Given this list of marker genes BOLA1, FASLG, HPX, EDN1, RHAG (NCBI Gene Id 6005), LYN, KCTD17, SCNN1B, CYP4F2, MT2A, MT1E, CNNM2, FLNA, PTH, GLUL, DRD3, ATP6V1G1, SELENOK, BAK1, SLC39A9, CA12 (NCBI Gene Id 771), TMTC4, TMEM94, HCRTR2, CALCA, KCNA1, CNR1, GRIK2, PRKCE, BNIP3, MIR1-1, ITPR3, SPX, FTHL17, MIR210, F2R, KCNA5, ASPH, COX10, ISCU, B2M, WNT5A, CCL15, ERC2, PLCL2, TMEM165, TRPV4, ATP2B3, CDH5, F2RL3 (NCBI Gene Id 9002), PACS2, TMCO1, ERFE, CYP27B1, TRPC5, XK, PDZD8, KEL, THY1, SLC12A6, IBTK, CASQ1, EDN2, MICU1, CCL5, PRKACA, CYB561, TF, SLC9B2, STK39, FTH1P19, CD19, CCDC47, CALR, SLC30A5 (solute carrier family 30 member 5), CYBA, HFE, NPPB, NOL3, SLC12A3, ANKH, ATP1A4, TRPV6, METTL21C, NUBP1, APP, CLCC1, SCNN1D, ATP2C2, BOLA2B, HJV, SLC12A9, TMTC2, CCL21, TMC6, KCNQ1, SLC31A1, ATP6AP1, NPSR1, PRND, STIM2, CORIN, ATP2A1, MLLT6, DRD2, SLC34A3, ANK3, PLN, CALM2, NHERF1, NTSR1, ATP1B1, SRI, RHD, ABL1, KCTD7, TPT1, CCDC115, EIF2AK1 (NCBI Gene Id 27102), GLRX3 (glutaredoxin 3), CCL19, TRPC4, CCL14, ATP6V1A, SLC39A14, PLCB3, STC1, TRDN, CCL11, ACVR2B, ATP6V1B1, CCL7, PDPK1, EDNRA, OTC, GHITM, PKHD1, MT3, CALM3 (calmodulin 3), AGT, THADA, SYPL2, PDE4D, NPY, KCNJ2, RHBG, ANKRD9 (NCBI Gene Id 122416), HCRTR1, ANK2, CHERP, SV2B, TNFSF11, ATP12A, CNNM1, HYAL2, IFNG, RMDN3, CIB2, XCR1, ATP4A, RAP1GDS1, PLCB2, S100A14, P2RY6, CX3CL1 (C-X3-C motif chemokine ligand 1), CLN3, MCUB, ATP4B, ZNHIT1, MT1A, P2RY1, TRPC1, PTH1R, KCNK16, SLC34A1 (solute carrier family 34 member 1), CCL23, HEPHL1, MYH7B, ALPL, TRPM8, PKD2, SCO2, RGN, SLC11A1, STEAP2, FXYD2, JPH1, SLC46A1, TRPA1, WNK4 (NCBI Gene Id 84361), SCN7A, DHRS7C, MIR93, ATOX1 (antioxidant 1 copper chaperone), TMPRSS3, RHCE, HAMP, CNNM4, MT1G, ITPR2, EPB42, HERPUD1, ELANE, CCDC22, ANXA6, FTMT, TMEM174, SLC10A7, TRIM24, HSP90B1, ATP2B4, OSBPL2, KL, CCR1, MT1H, ATP1A3, SLC35G1, TRPC3, PLCE1, C19orf12, BOLA2, HTT, STEAP4, PLCG1, EDNRB, BOK, SMAD1, SOD2, ATP13A2, SLC34A2, SLC1A3, WNK1, CCL3, CYP4F12, YWHAE, GPER1, SLC30A7, CEMIP, SNX10, SGCD, IL13, TMEM203, GSTO1, GRID2IP, NCOA4, SLC22A17, COX19, CALB1, NEO1 (neogenin 1), SLC39A4, SLC31A2, GPR12, TRPC7, CYP4A11, CORO1A, P2RX1, FGFR1, MAIP1, ENPP1, FLVCR1, LCN6, DRD1, SLC12A1, CXCR3, CACNA1S, TMEM38A, NPTN, TFR2, ATP2B1, SLC24A2, PTPN6, SLC39A8, GCM2, SLC24A1, TFRC, CAV2, TMPRSS6, HEXB, SLC1A1, ATP2A2, SMAD4, CUTC, MC3R (NCBI Gene Id 8203), ATP7B, TRPM2, PTPRC, SLC12A5, MECR, BCL2, CTRC, FECH, MT1M, PLCL1, CYP11B2, MCU, JPH4, BOLA3, TMC8, CXCL9, ATF4, SNCA, LCK, DISC1, RYR3, CLIC2, CD40, GRM5, HTR2B (NCBI Gene Id 3357), ADORA1, CHD7, CP, PLCH1, PRNP, MICU3, TPCN2, XIAP, TMEM38B, GSTM2, ENPP3, PTK2B, DRD4, SLC17A6, TGFB1, TRPM7 (transient receptor potential cation channel subfamily M member 7), CHRNA7, FKBP1A, FZD9, SPPL2C, FBXL5, STOML2, FTH1, SLC39A7, SLC30A2, CACNB2, GP5, SLC8A2, UPK3A, IL1A (interleukin 1 alpha), MYC, KCNMA1, FTL, XPR1, EXT1, BMP6, TRPV5, FKBP1B, ABCC6, SLC39A13 (NCBI Gene Id 91252), PML, TMEM178A, SLC12A7, LETMD1, FGF2, COMMD1, ABCB6, SV2A, FRRS1, CCR7, TMEM199, APLNR, ATP1A1, CASQ2, VAPB, ATP1B2, SLC17A8, HRC, EXT2, KDR, CISD1, GRM1, CCR2, HAP1, SLC25A27, PLCB1, SLC17A7, SLC8B1, DDIT3, AFG3L2 (AFG3 like matrix AAA peptidase subunit 2), HEPH, TMBIM6, SLC11A2, STIM1, IREB2, NAGLU, LCN2, ATP2C1, NPPC, PRKCB, WBP2NL, SLC12A8, MCOLN1, ATP6V0A2, TUNAR, P2RX7, DIAPH1, CAPN3, TBXAS1, LIME1, PSEN1, ATP13A4, FAM3A, F2, BDKRB1, GRINA, SLC8A3 (solute carrier family 8 member A3), SLC41A1, ATG5, SLC24A5, ALAS2, IMMT, CXCL11, CXCL12, CYBRD1, AP3B1, MT1F, RYR1, SCO1, PLCH2, CAV3, CAMK2D, SOD1, HTR2C, ADCY8, FAM20A, AKAP6, SLC30A9, FXN, FGFR4, CNGB1, DMTN, ATP13A1, NGF, RYR2, AGTR1, APOE, CDH23, CSRP3 (cysteine and glycine rich protein 3), CACNA1C, CXCL10, ITPR1 (NCBI Gene Id 619543), PSEN2, CCL13, ATP1A2, MT1B (NCBI Gene Id 81836), SCNN1A, CASR, NPR1, MT1X, MT4, TRPC6, SLC39A10, PLCG2, MTLN, HTR2A (NCBI Gene Id 3356), SLC9A1, UMOD, CCL8, PLCB4, KCNE3, TGM2, KLHL3, SLC25A23, CALB2, ATP2B2, PICALM, SCARA5, ATP1B3, CCL1, CCR5, TCIRG1, TTC7A, JPH3, SLC30A8, SLC30A10, EGLN1, MCUR1, XCL1, STC2, COMT, SLC8A1, MICU2 (mitochondrial calcium uptake 2), GP9, KCNH2, HIF1A, CALCB, ATP13A3, DRD5, PIK3CB, UBASH3B, ATP6V0D1, FGF23, GP1BB, BTBD9, GDF2, ACO1 (aconitase 1, NCBI Gene Id 48), MT1DP, ITGB3, SELENON, SCNN1G, GLRX5, ERO1A, LETM1 (leucine zipper and EF-hand containing transmembrane protein 1), TSPOAP1, SMAD5, ATP7A, CAV1 (NCBI Gene Id 857), EPAS1, NDFIP1, SLC12A4, SLC24A4, CALM1, KCNJ10, LACRT (NCBI Gene Id 90070), SLC40A1, SLC30A1, SMDT1, ARF1, ATP13A5, CACNB4, ATP2A3, SLC39A6, RHCG, SLC24A3, CNNM3, MT1HL1, PRKD1, SMAD9, JPH2, CYB561A3, SLC12A2, TNNI3, SFRP4, VDR, MIR133A1, EDN3, GP1BA, NT5E, TMEM64, WFS1, BAX, ABCB7, VPS54, CIB3, DMD, FATE1, HMOX1, DMPK, GRIN1, here is a description of the gene set: Human Gene Set: GOBP_INORGANIC_ION_HOMEOSTASIS species: Homo sapiens Any process involved in the maintenance of an internal steady state of inorganic ions within an organism or cell.